The following is a description of a gene set: The process in which the branching structure of the mammary gland duct is generated and organized. The mammary gland is a large compound sebaceous gland that in female mammals is modified to secrete milk. Mouse Gene Set: GOBP_BRANCHING_INVOLVED_IN_MAMMARY_GLAND_DUCT_MORPHOGENESIS species: Mus musculus, and this is the list of marker genes: Pml, Lrp6, Tfap2c, Ddr1, Vdr, Areg, Pgr, Med1, Ccl11, Tgfb1, Msx2, Csf1, Etv4, Phb2, Wnt5a, Esr1, Wnt4, Csmd1, Etv5, Ncoa3, Lrp5, Src, Cav3, Ar, Btrc, Kdm5b, Epha2, Slc12a2, Tbx3